The following is a description of a gene set: Human Gene Set: HP_ABNORMAL_PITUITARY_GLAND_MORPHOLOGY species: Homo sapiens An anomaly of the pituitary gland. Abnormal pituitary gland morphology, and this is the list of marker genes: BMP15 (NCBI Gene Id 9210), CTSK, FIGLA, KMT2D, ADNP, ZMYND15, BRAF, FLRT3, MSH5, ZFX, SOX3, MTHFR, SRD5A3 (steroid 5 alpha-reductase 3), GPR161 (NCBI Gene Id 23432), WDR4, EDA (NCBI Gene Id 90878), GNAS, ARNT2, ESCO2, POU3F4, DYRK1A, SHH, CDKN1B, FOXL2, KDM1A, CEP57, MRPS22, SNRPN, MSH4, VSX1 (NCBI Gene Id 8198), PMS1, ATRX, TACR3, HID1, PNPLA6, CCDC141, NF2, SIX6, ZSWIM7, TP53, TMCO1, COQ6, MPDU1, SRPX2, BRCC3, CLPP, SMARCB1, PNLDC1, MANF, IFT140, TP63, SHOC1, MOV10L1 (NCBI Gene Id 54456), MT-ATP8, STIL, NDNF, PROP1, HS6ST1, DUSP6, FSHB, BMP4, RNPC3, KASH5, SYCP2L, CHEK2, TSC1, CYP11A1, RPL10L, FGF17, MAP3K1, ACP5, SLC29A3, ZFPM2, SOX9 (SRY-box transcription factor 9), PUS1, NDN, SYCP3, POLD1, TGFBR2, TRAF7, NONO, YY1, LIG4, PKD2, SEMA3A, CNBP, SNORD116-1, MAST3, GLI2, TBX19, OTX2, FKBP6, IFT56, SUFU, CRIPTO, MCM8 (NCBI Gene Id 84515), CYB5A, BNC1, EDA2R, IDH1, NFKBIA, DCC, IDH2, HSD3B2, FGF8, CT55, LEP, SPAG17 (NCBI Gene Id 200162), DLL1, PRLR, MCM4, BPTF, PDE11A, SOX2, ABCD1, KCNJ11, TMEM67, SEMA4A, POLR3A, TERT, VPS13B, PITX2, USP8, CDKN2B, HSD17B4, FEZF1, ATM (ATM serine/threonine kinase), ZIC2, ALG9, TBCE, RRM2B, POLA1, NSUN2, SRY (sex determining region Y), GAS1, DHX37, DISP1, KMT2A, KATNIP, CTNNB1 (NCBI Gene Id 1499, catenin beta 1), EFL1, CHD7, POLR3H, NSMCE2, SMARCE1, VANGL2, AXIN1, DNAH10, ESR1, TSHB, SYCE1, SEMA3E, PSMD12, BMPR1B, B3GLCT, ERCC6, TGIF1, GAN, PWRN1, TAF4B, OCA2, LHX3, USP48, BAP1, STAT5B, GHRHR, FSHR, GMNN, STX16, KLHL10, MSTO1, BTK (Bruton tyrosine kinase), PTDSS1, PROKR2, GATA6, HROB, CBX2, BRCA2, PSMC3IP, HESX1, DNAJB11, RNU4-2, MEIOB, ARMC5 (NCBI Gene Id 79798), TDRD9, SIM1, XRCC2, CDKN1C, SMO, SPIDR, DBH, BMPR1A, FOXH1, HERC2, NKX2-1, APOA5, FMR1, SIN3A, POR, PLCH1, PTCH1, GRB10, SOX11, MSH6, PMS2, MED12, RNF212, WT1, NR3C1, CDKN2A, DDC, FLNB, DMXL2, FARSA, NR0B1, POU1F1, TEX15, LHX4, FBXO43, SPRY4, DNAJC21, KISS1R, PI4KA, NR5A1, TERB2, AFF4, CDC42BPB, PKD1, FANCM, ADGRG1, PREPL, DNHD1, CDH23, FGFR1, PDGFB, MSH2, VAMP7, TSC2, RFWD3, GCNA, SIX3, DIAPH2, IL17RD, LARS2 (NCBI Gene Id 23395), PRKAR1A, FANCI, PIK3CA, SBDS, TRHR, PMM2, IGSF1, IGF2, FGD1, SOHLH1, RRAS2, AKT1, SMAD2, ADAT3, GANAB, ANOS1, THOC2, PROK2, ALG5, ZNF462, CDON, TEX14, RNF113A, WWOX (WW domain containing oxidoreductase), CYP17A1, STAG2, WDR11, ERF, EIF2S3, MADD, HBB, EPCAM, GRM7, POLR3GL, GHSR, BICC1, GPR101 (NCBI Gene Id 83550), NODAL, LZTR1, POLE, GATA4, SPATA22, STAG3, CFTR, TBCK, IARS2, HPGD, CATIP, SLCO2A1, NFKB2, MEN1, CDKN1A, APC, MT-TL1, KANSL1, NUP107, GH1, MCM9, GNB2, POMC, GDF9, COG2, SNORD115-1, TERB1, ALX3, MAP2K2, TBX2, MKRN3 (makorin ring finger protein 3), PPP2R3C, PUF60, NDE1, FANCF, KRAS, DHH, MUTYH, MAGEL2, SMC1A, AR, PWAR1, IGF1, LHB, KIAA0753, PDHA2, CCDC34, ZSWIM6 (NCBI Gene Id 57688), CDKN2C, IFNG, ALMS1, C14orf39, ESR2, IKBKG, FOXA2, RPS20, GLI3, HFM1, KDM6A, LEPR, ZNF148, RBM28, ROBO1, TEX11, AIP, ZNRF3, PCSK1, SLC7A7, TBX3, SOX10, NANOS1, MLH1, SLC30A7, LHCGR, NPAP1, WASHC5